Given this list of marker genes POLG2, TCEAL4, SLC26A2, BYSL, NME6, EIF4A1, CBR4 (carbonyl reductase 4), SNX2, CEP68, TP53, GABPB1, CKS2, here is a description of the gene set: Human Gene Set: CHEOK_RESPONSE_TO_MERCAPTOPURINE_UP Genes specifically up-regulated in pediadric acute lymphoblastic leukemia (ALL) patients by mercaptopurine. To elucidate the genomics of cellular responses to cancer treatment, we analyzed the expression of over 9,600 human genes in acute lymphoblastic leukemia cells before and after in vivo treatment with methotrexate and mercaptopurine given alone or in combination. Based on changes in gene expression, we identified genes that accurately discriminated among the four treatments. Discriminating genes included those involved in apoptosis, mismatch repair, cell cycle control and stress response. Only 14% of genes that changed when these medications were given as single agents also changed when they were given together. These data indicate that lymphoid leukemia cells of different molecular subtypes share common pathways of genomic response to the same treatment, that changes in gene expression are treatment-specific and that gene expression can illuminate differences in cellular response to drug combinations versus single agents. from publication Cheok MH, Yang W, Pui CH, Downing JR, Cheng C, Naeve CW, Relling MV, Evans WE (PMID 12704389) species: Homo sapiens